The following is a description of a gene set: Movement of a vesicle along an actin filament, mediated by motor proteins. Mouse Gene Set: GOBP_VESICLE_TRANSPORT_ALONG_ACTIN_FILAMENT species: Mus musculus, and this is the list of marker genes: Wasl, Myrip, Myo5a, Fnbp1l, Actn4, Myo1c